Given this list of marker genes SUMO1, SUMO3, SUMO2, UBA2, SAE1, here is a description of the gene set: SUMO is conjugated to E1 (UBA2:SAE1) Human Gene Set: REACTOME_SUMO_IS_CONJUGATED_TO_E1_UBA2_SAE1 studied in species Homo sapiens